The following is a description of a gene set: from publication Gil MP, Ploquin MJ, Watford WT, Lee SH, Kim K, Wang X, Kanno Y, O'Shea JJ, Biron CA (PMID 22968462) Human Gene Set: GSE40666_STAT1_KO_VS_STAT4_KO_CD8_TCELL_WITH_IFNA_STIM_90MIN_UP studied in species Homo sapiens Genes up-regulated in CD8 T cells treated by interferon alpha: STAT1 knockout versus STAT4. Type 1 IFNs can conditionally activate all of the signal transducers and activators of transcription molecules (STATs), including STAT4. The best-characterized signaling pathways use STAT1, however, and type 1 IFN inhibition of cell proliferation is STAT1 dependent. We report that type 1 IFNs can basally stimulate STAT1- and STAT4- dependent effects in CD8 T cells, but that CD8 T cells responding to infections of mice with lymphocytic choriomenigitis virus have elevated STAT4 and lower STAT1 expression with significant consequences for modifying the effects of type 1 IFN exposure. The phenotype was associated with preferential type 1 IFN activation of STAT4 as compared to STAT1. Stimulation through the TCR induced elevated STAT4 expression, and STAT4 was required for peak expansion of antigen-specific CD8 T cells, low STAT1 levels, and resistance to type 1 IFN-mediated inhibition of proliferation. Thus, a mechanism is discovered for regulating the consequences of type 1 IFN exposure in CD8 T cells, with STAT4 acting as a key molecule in driving optimal antigen-specific responses and overcoming STAT1-dependent inhibition of proliferation., and this is the list of marker genes: UCK1, TRAPPC2, RALGAPB, PRAF2, CHCHD5, SOWAHC, PLPP6, ACO2, LZTFL1, USP32P2, MVB12A, PLCL1, GLCE, STK36, ZNF436, PRL (prolactin), DPY19L4, CYB561D2, DHX38, DPP8, DTWD1, PRRG4, RHOT2, CCDC77, WDR59, MTA3 (NCBI Gene Id 731342), USP16, DHRS4-AS1, LRRC37A2 (leucine rich repeat containing 37 member A2), SPACA9, SMCHD1, WDR19, LSM10, ARHGAP19, CNTRL, DHRSX (NCBI Gene Id 207063), DCP1B, SUSD3, ZNF10, PRXL2B, RABGGTA, DUSP18, MIS18A (MIS18 kinetochore protein A), COMMD3, XPO4, ACSL4, NIF3L1, SPAG7, GRAMD2B, NR1H2, IFT172, ZFP91, PSMG1, HNRNPUL2, PRKCD, LNPK, GLTP, INTS7 (NCBI Gene Id 25896), TERF1, TALDO1, CDKN1B, WDR35, NAGS, TNFAIP8L1, PFKM, NOVA1, CNOT2, KBTBD6, GP5, FARS2, ASXL1, EHBP1L1, METTL25B, ANKRD50, ZNF256, FBXL17, CIP2A (cellular inhibitor of PP2A), CCDC117, MBD5, MEN1, PYGO2, TAF7L, RSPRY1, TXNDC11, PLEKHG7, GMPS, MIA2, CCDC137, FAM50B, GSTA1, COQ6, SLC25A34, PKD2, OGFOD3, GLT8D1, PRKD2, TACC3, COG5, RBM42, EMC10, SETDB1, NUDT6, ANKZF1, CYREN, AKT1S1, MVP, KCTD14, EIF3H, IRF2, MTNAP1, RALGAPA2, GIMAP8, ZNF174, NAP1L4, TRMT2A, TOP3A, SHKBP1, TXK, KATNIP, ERLEC1 (endoplasmic reticulum lectin 1), BUB3, FOXRED1, KATNA1, AQR, PARP3, NCAPG2, MSH3 (NCBI Gene Id 4437), ARAF, IDH3G, RTF1, PARP15, MYCL (NCBI Gene Id 4610), TFDP2, FAM86B1 (NCBI Gene Id 85002), VIRMA, SLC25A39, PIK3CA, TYK2, RFXANK, SKAP2, ZNF226, C1orf21, ZFYVE1, NR3C1, LANCL2, CYTH1, BBS12, SIK3, ZNF519, HMGB3P1, LXN, ZCCHC24, SLC2A4RG, EEPD1, CAMTA2 (calmodulin binding transcription activator 2), BCOR, ATG9A, PRMT6, WSB1, NCOA1, EXOC3, ZMYM2, DIS3L, MARK3, ZNF250, LRRC8D, RPS11, H2BC3, APEH, NADSYN1, FAU, CYC1, COX5B, CFAP36, NKIRAS2, ADRM1, KCNK1, CCDC7, DGCR8, PPP1R3D, DCT, MRPL41, KIAA0319L, CCDC159, HTR2B, PRCC (NCBI Gene Id 5546), EFTUD2, MCM5, NRGN, RNF123, KLHDC1, TTC38, ZNF230, SUPT20H, XRCC5